The following is a description of a gene set: Genes up-regulated by 2-methoxyestradiol (2ME2) in the MM.1S cell line (multiple myeloma) sensitive to dexamethasone. Our previous study demonstrated that 2-methoxyestradiol (2ME2), an estrogen derivative, induces apoptosis in multiple myeloma (MM) cells; however, the related transcriptional events are unclear. In the present study, we used oligonucleotide microarrays to identify genes altered during 2ME2-induced apoptosis in MM cells. 2ME2 triggers an early transient induction of genes known to trigger cell death and repression of growth/survival-related genes. Many genes regulating cell defense/repair machinery also were transiently induced. Since 2ME2 also induces apoptosis in MM cells resistant to conventional therapies such as dexamethasone (Dex), we compared the gene profiles of 2ME2-treated and Dex-resistant MM cells. Our results suggest that 2ME2 overcomes Dex resistance by modulating genes that confer chemoresistance in MM cells. Microarray results were confirmed by Northern and Western blot analyses. A comparative analysis of selected genes from freshly isolated MM patient cells and 2ME2-treated MM.1S MM cells further provides an in vivo relevance of our in vitro studies. Collectively, these findings suggest genetic events mediating anti-MM activity of 2ME2, as well as mechanisms whereby 2ME2 overcomes Dex resistance in MM cells. These studies may therefore allow improved therapeutic use of 2ME2, based upon targeting genes that regulate MM cell growth and survival. from publication Chauhan D, Li G, Auclair D, Hideshima T, Richardson P, Podar K, Mitsiades N, Mitsiades C, Li C, Kim RS, Munshi N, Chen LB, Wong W, Anderson KC (PMID 12480690) species: Homo sapiens Human Gene Set: CHAUHAN_RESPONSE_TO_METHOXYESTRADIOL_UP, and this is the list of marker genes: GPR161, PRODH, CBX6, DNAJA1, HSPA8, TARDBP (TAR DNA binding protein), AARS1, SLC3A2, SRSF6, RBM3, PSMD1, UBE2G2, ASNS, CKB, C1QL1, PTTG1, CKS2, CARS1, HSP90AA1, TIMM44, PPIL2, SNRPD3, UBE2M, WNT11, DENND2B, ATF4, SRSF2, TRBC2, HDGF, UBE2L3, YARS1, CIRBP, EIF5AL1, MYC, UBE2S, COX7B, NBPF14, RBPMS, NME1, SLC7A5, CCNB1, HMGN2, SRM, CHMP7, DUSP10, AHSA1, PMM2, GARS1 (glycyl-tRNA synthetase 1), CRYBB1, ITGB5 (NCBI Gene Id 3693)